Given this list of marker genes CACNB2, CACNB3 (calcium voltage-gated channel auxiliary subunit beta 3), KCNA3, TPCN2, KCNS1, CYBB, KCNJ15, KCNH6, KCNJ14, CAV1, CACNA1I, SNAP25, KCNQ1, KCND2, HCN1, CACHD1, CACNA1E, CACNA1G, CACNG4, TMC2, CATSPER2, CACNA1F, CACNB4, KCNJ4, TRPA1, KCNJ1, KCNG4, KCNN1 (NCBI Gene Id 3780), LRRC26, KCNIP2, GRIN2D, KCNC2, CALHM1, KCNJ5 (potassium inwardly rectifying channel subfamily J member 5), CACNG2, LRRC38, CACNA2D3, KCNK3, KCNH8, KCNV1, CACNA2D2, KCNQ3, TSPOAP1, CACNG1 (NCBI Gene Id 786), KCNE4 (NCBI Gene Id 23704), TRPV1, KCNS3, KCNJ9, KCNAB1, KCNJ6, CACNA2D4, KCNQ2, HCN3, KCNA6, TMC1, KCNAB2, LRRC52, KCNK6, KCNJ13, KCNE3, CATSPER1, CATSPER4, KCNN3, CACNA1H, SCN2B, KCNA2, KCNT1, LRRC55, KCNK1, CACNA1A, CACNA1C, KCNAB3, KCNH3, KCNC1, KCNT2, KCNJ11, KCNC3, KCNV2, KCNE5, OPRM1, KCNE2, CACNG5, KCNE1, KCNK18, PKD2, KCNMA1, HCN2, CACNG8, KCNJ3, CACNG6, KCNA10 (potassium voltage-gated channel subfamily A member 10), KCNG2, KCND1, CACNG3, KCNQ5, KCNA7, KCNK12, KCNG1, KCNJ16, CACNA1S, KCNN2, KCNK17, KCNH1, KCNJ2, CACNA2D1, KCNK10, TMEM109, CACNG7, KCNF1, KCNK4, KCNG3, HVCN1, KCNA1 (potassium voltage-gated channel subfamily A member 1), ABCC9, KCNK7, KCNB2, RYR1, ITGAV, KCNJ12, NCS1, CACNB1, KCNK5, KCNQ4, KCNA5, KCNH2, KCNS2, KCNA4, KCNK16, KCNK13 (NCBI Gene Id 56659), KCNK2, KCNH4, ABCC8, KCNJ8, CATSPER3, KCND3, KCNH7, KCNK9, KCNC4, KCNH5, CACNA1D, KCNJ18, KCNJ10, HCN4, KCNB1, CACNA1B, here is a description of the gene set: species: Homo sapiens Enables the transmembrane transfer of a cation by a voltage-gated channel. A cation is a positively charged ion. A voltage-gated channel is a channel whose open state is dependent on the voltage across the membrane in which it is embedded. Human Gene Set: GOMF_VOLTAGE_GATED_MONOATOMIC_CATION_CHANNEL_ACTIVITY